Given this list of marker genes Ajap1, Pard6b, Gtsf2, Mbnl2, Abhd3, Vps4b, Aqp3, Kras, Gnrhr, Pkia, Btbd10, Itgb1bp1, Tjp1, Sema3d, Stag2, Tardbp, Trib2, Piga, Ttc39a, Rcan2, Eaf1, H2al2a, Armc6, Cd200r4, Rhoq, Ptp4a2, Usp6nl, Vcp, Bbx, Nmnat2, Zfp644, Trmt10b, Ube2d3, St6galnac5, Tmem245, Srek1, Pcdh9, Dmrt1, Mavs, Rcbtb1, Camk1d, Shprh, Gli2, Cacna2d3, Tmem65, Tomt, Orc4, Cdkl2, Cdh6, Nfkb1, Ptprg, Slc34a1, Apmap, Tslp, Adamts17, Zswim6, Nxph1, Maml2, Trim14, Hlcs, Nsd2, AU040320, Atp1b3, Mad2l1, Tpp2 (tripeptidyl peptidase II), Exd2, Naa30, Kcnd2, Zdhhc17, Fbxo4, Wwox, Ccdc89, Minar1, Ppp2r5d, Fbxw4, Ewsr1 (Ewing sarcoma breakpoint region 1), Pitpnb, here is a description of the gene set: from publication Chen Y, Wang X (PMID 31504780) species: Mus musculus Mouse Gene Set: MIR_6411 Genes predicted to be targets of miRBase v22 microRNA mmu_miR_6411 in miRDB v6.0 with MirTarget v4 prediction scores > 80 (high confidence targets).